The following is a description of a gene set: species: Mus musculus The neural regulation of blood pressure in which baroreceptors sense the amount of stretch occurring in vessels and respond to the input via central nervous system control. Mouse Gene Set: GOBP_REGULATION_OF_SYSTEMIC_ARTERIAL_BLOOD_PRESSURE_BY_BARORECEPTOR_FEEDBACK, and this is the list of marker genes: Calca, Adra1d, Adra1a, Nav2, Chrna7, Adra1b (NCBI Gene Id 11548, adrenergic receptor, alpha 1b), Asic2